The following is a description of a gene set: Genes predicted to be targets of miRBase v22 microRNA hsa-miR-6728-5p in miRDB v6.0 with MirTarget v4 prediction scores > 80 (high confidence targets). Human Gene Set: MIR6728_5P studied in species Homo sapiens from publication Chen Y, Wang X (PMID 31504780), and this is the list of marker genes: TPBGL, ENO2, DACT2, RSPO3, FOXN1, DDAH1, AUTS2, KDM4D, RBL2, RBMS3, CBLN2, ATN1, RPL27A (ribosomal protein L27a), BSDC1, SFRP5, EDNRB, HAPLN1, GPR158, ATP2B1, GBP3, KCTD4, RHOT1, H2AZ2, CEP128, STX12, MAP3K8, R3HDM2, ZCRB1, ADIRF, NR3C1, FAM171B, APLP1, SATL1, SHCBP1, BCAN, HPS3 (NCBI Gene Id 85393), BRWD1, LIN54, PHACTR2, ADAM22, PPTC7, SLC1A3, PAX3, NLGN1, PEX19, ERC1, CSMD2, CDH24, NUTM1, CLCA4, GALP, POLDIP3, CALCOCO1, FAM47E-STBD1, ERI1, CHPF, DNAJC16, FLT3LG, BCL6, ILDR2, ALOXE3, MMAB, SPAG8, DCAF8, TTI2, FAM89A, SP6, COL9A3 (NCBI Gene Id 1299), RPS6KB1, GNA14